Given this list of marker genes Ero1b, Qsox2, Qsox1, P4hb, Gfer, Ero1a, here is a description of the gene set: species: Mus musculus Mouse Gene Set: GOMF_THIOL_OXIDASE_ACTIVITY Catalysis of the reaction: 2 R'C(R)SH + O2 = R'C(R)S-S(R)CR' + 2 H2O2.